The following is a description of a gene set: Human Gene Set: GSE24142_EARLY_THYMIC_PROGENITOR_VS_DN3_THYMOCYTE_FETAL_DN Development of T-cells provides a unique opportunity to study cell-fate determination due to the accessability and the well defined stages of developmental stages. In order to understand the genetic programs underlying fetal and adult T‑cell fate specification we subjected highly purified fetal and adult T-cell progenitor populations to a genome‑wide transcriptional analysis. The aim was to identify molecular elements that govern T-cell fate specification as a whole but ultimately to isolate elements that were specific for a given population in a specific developmental window. Genes down-regulated in comparison of thymic progenitors versus fetal DN3 thymocytes. species: Homo sapiens from publication Belyaev NN, Biró J, Athanasakis D, Fernandez-Reyes D, Potocnik AJ (PMID 22581009), and this is the list of marker genes: STAMBPL1, SNRK, NEDD4L, EDEM1, BCKDHA, RGCC, DLST, EHD3, DNAH8 (dynein axonemal heavy chain 8), MYL10, DUSP10, HIVEP3, PAG1, RCAN3, CHD7, PTPN13, GIPC2, ARHGEF10L, PTPRO, LLGL2, SLC2A3, TRAF1, BTG1, STAT1, MYL11, ACTN1, CYB5A, GBP6, MBP, TBCA, CDC42EP1, DNMBP, TXNDC16, SYNE2, LEF1, PEX6, RAB33A (RAB33A, member RAS oncogene family), AGFG1, MGST2, EIF2AK3, CYP2J2, HUNK, PRRT1, EHHADH, MTF2, VCF1, ERBB3, TUBB2A, FYB1, SCML4, MAN1A1, TXK, MPG, CACNA2D2, GALNT2, SATB1, WSB2 (WD repeat and SOCS box containing 2), HSD11B1, MYOF, HEYL, GRB7, SETD4, HIBADH, CDK5RAP2, SYTL3, SH3BGRL2, MIA2, ITPR2, ABCC5, CLK3, TMEM230, FBXO25, EZR, CAMKV, DEDD2, RSPH1, TAB1, REC8, ATG12, EDARADD, DHX40, CDK20, CLDN4, DSG2, SLC37A2, ALDH7A1, PLD3, SYNE1, SLC66A3, EVI5, DNAI4, DIPK2A, CDKN2C, HDAC11, BRDT, SIN3B, PKP3 (NCBI Gene Id 11187), ADCY6, CTNND2, TUBB2B, METTL8, CUX2, HDAC7, SPG11, TNFAIP8L1, RFXANK, ANKRD46, DOCK6, LMO7, PRKCB (NCBI Gene Id 5579), ASB8, ERN2, ITK, IGF2, PTRH1, MPP1, DYNLT5, LIPG (NCBI Gene Id 9388), TEC, LDHB, LRRC42, TGFBR1, HSDL2, TOLLIP, NCK2, PLXDC1, TMEM38A, SIDT2 (NCBI Gene Id 51092), CD8B, FICD, CBLN1, DAPK1, EIF3I, IFNGR1, XBP1, CYTH1, PDLIM5, NATD1, KDM8, ITGB4, TRIM24, GPR132, IZUMO1R, IGF2-AS, IL10, RAB6B, CD164, ASB4, AP3M2, PGF, KCNJ9, KLC3, GFI1, ENTPD5, EFEMP2, CRIM1 (NCBI Gene Id 51232), PPP3CB, LBX1, TM7SF2, IL5RA, GSK3A, TMC6, DGKE, NOTCH1, MBTPS1, RRAS2, ATP8A1, TBXA2R, TMEM131, RASGRF1, RAB20, PMM1, SLA2, ATP1B1, DBP, BCL11B, SLC35D1, VEGFA, ATG4D, PRADC1, NDRG2, POLD1, NR3C1, CLEC11A, TMEM120B, ARHGAP9, TM6SF1 (NCBI Gene Id 53346), DNLZ, SPATS2, DLG3, SHISA5, TLE3, PHTF1, MED20, RAG1, ADRB2, NOTCH3, CERK, PMEPA1